Given this list of marker genes CFAP44, ANKDD1B, DIO1, AGBL2 (AGBL carboxypeptidase 2), FLACC1, SERPINI2, DNAH6, PPIL6, ENO4, ZSCAN1, ENSG00000263011, ANKFN1, CLUAP1, FRMPD2, IFT70A, DNAAF4, CCDC33, UBXN10, DNALI1, TOGARAM2 (NCBI Gene Id 165186), CFAP95, RPGR, RSPH10B2, DNAH7, CETN2, CFAP100, LINC02958, LINC00939, DAW1, TP73, DNAAF8, LINC01765, TTC23L, AKAP14, HHLA2, ENKUR, EFCAB6, SPATA33, CFAP144, GLB1L2, CCNO-DT, TTLL10 (NCBI Gene Id 254173), HCG14, FOXJ1, SEC14L3, MAT1A, HYDIN, GLTC1, LINC00589, TSPAN19, TEX26, FMO3, ENKD1, EEF1B2P5, LINC01927, C7orf57, UGT2B17, LRRIQ3, LRRC18, SMIM34, C10orf67, IQCG, SAMD15, CFAP210 (cilia and flagella associated protein 210), RSPH14, RPGRIP1L, WDR93, CCDC74B, DPCD, DNAAF11, CFAP52, DZANK1, PAPOLA-DT, LRGUK, CCDC160, FAM181A, CSRP3-AS1, LINC01435, CFAP54, TMPRSS7, PACRG, IL5RA, CC2D2A, DNAI7, ZNF391, LRRC71, CFAP77, FABP6, CDH13-AS2, SPATS1, ZNF273, SLC28A2, TEKT3, CEP126, KIF27, LINC02624, CIMAP1B, CACNG6, FAM227A, MAK, C1QTNF8, BBOF1, CFAP184, FBXO15, FAM216B, TMEM231, TMEM190, CCDC74A, LGSN, FBXW9 (F-box and WD repeat domain containing 9), NHLRC4, VWA3A, E2F3P2, CCDC13, RPL30P7, C1orf141, LINC02289, CCDC170, GJB7, ENSG00000228793, LRRC34, SLC9C2, KIAA2012, NPHP1, CFAP69, LRRIQ1, LRRC37A5P, DNAH10, C21orf58, TREM1, LRRC56, HAGHL, CCDC65, LINC02166, RABL2A, CFAP126, VWA3B, HOATZ, DNAH5, ALDH3B1, LRP2BP, DLG5-AS1, ERICH3, DYNLRB2-AS1, ROPN1L, ESRRG, ZMYND12, ANKK1, TEKT4, GBP6, IFT56, MROH9, LCA5L, PPP1R16A, ZNF475, SPACA9, SPEF2, MORN2, CCDC181, KCNJ16, DYDC2, SLC44A4, FBXL13, LINC01392, ENSG00000258752, DNAI2, CAPN13, USP2, DNAI3, ST6GALNAC2, DNAL1, TIGD4, CNGA4, TMEM212, MDH1B, MGAT4D, FAM151B-DT, CCDC78, VNN3P, CCDC60, SPATA18, WDR49, EFCAB10, LIAT1, ENSG00000236495, CCNO, LDLRAD1, MAP3K19, CSPP1, EEF1B2P4, DCDC2B, GIHCG, LMNTD1, LINC02066, C8orf34, NWD1, ODAD2 (outer dynein arm docking complex subunit 2), LCA5, TTC41P (NCBI Gene Id 253724), SLC22A4, TUBA4B, C22orf23, SAXO4, TMEM67, APOBEC4, ADPRS, GOLGA2P5 (GOLGA2 pseudogene 5), CDH26, PPP1R42, R3HDML-AS1, ZNF295-AS1, SPMIP6, CIMIP1, CFAP61, SAXO2, PLEKHS1, CD164L2, TEKT1, TPPP3, CASC2, RSPH4A, DNAI1, CFAP221, FHIP1A-DT, C22orf15, CIMIP5, DNAAF2, TMEM232, ERICH3-AS1, CATSPERD, TSNAXIP1, TP53AIP1, AK9, FSIP1, SYT8, PRSS54, LRRC26, ARMH2, FUZ, IQUB, SPAG8, CCDC39-AS1, RIBC1, LRRC10B, FHAD1 (forkhead associated phosphopeptide binding domain 1), DTHD1, TTLL9, SOX30, CFAP107, RSPH10B, STMND1, B9D1, UROC1, LINC01708, WFDC6, LMO1, ENSG00000238185, RPL13AP26, MIR7515HG, C11orf97, NME5, C10orf95, KIF23-AS1, LRRC43, MNS1, THBS3-AS1, SLC27A2, DYNLT5, GON7, PLA2G10CP, ANXA13, LRRC9, CFAP73, RSPH9, CFAP263, FANK1, FAM133GP, WDR38, HMGB1P16, DNAH3 (dynein axonemal heavy chain 3), CFAP418-AS1, FOXN4, GAS2L2, IK, CCNA1, EFCAB12, TTC14-DT (TTC14 divergent transcript), KIF9, TCTN2, ARMC3, FAM221B, PLPPR3, CLEC19A, CFAP298 (cilia and flagella associated protein 298), CCDC103, LKAAEAR1, ENSG00000234022, CFAP65, DYNLT4, WDR86-AS1, CCDC89, TEX56P, CFAP91, CIMIP2C, RUVBL2, ADGB, ENSG00000228944, ODAD3, ANGPTL5, FAM47E, LINC02265, ODAD1, ZDHHC11 (NCBI Gene Id 79844), CFAP45, C6orf52, SNTN, EFHB, RNF32, USP2-AS1, CAPN8, TTC29, CFAP90, DNAAF1, FAM181A-AS1, LRRC73 (leucine rich repeat containing 73), ANKRD66, MRLN, RGS22 (regulator of G protein signaling 22), RABL2B, LINC02731, RSPH1, ZNF584, DNAI4, EMC3, GSTA3, TTC21A, IFT57, LRRC23, SYNPR-AS1, TTC34 (NCBI Gene Id 391205), LEKR1, CFAP119, RP1, CFAP206, TGM3, FAM229B, CFAP141, AK8, CFAP99, ADGRF2P, PIERCE2, HSPBP1, ZNF19, ZDHHC1, DNAH1, LRRC46 (leucine rich repeat containing 46), NEK5 (NIMA related kinase 5), ERICH2-DT, DYNLRB2, LINC01707, CABCOCO1, ATP4B, ARMH1, CFAP276, OSCP1, SCGB2A1, CCDC146, SPAG16, STK33, CLDN8, ZNF473CR, ULK4, RIIAD1, CFAP70, ARMC2, RHPN1-AS1, SRGAP3-AS2, RPL21P54, GSTA2, ANKRD44-AS1, NRAD1, CDNF (cerebral dopamine neurotrophic factor), SMIM6, LRRC78P (NCBI Gene Id 651551), KIF6, DRC1, SAPCD1-AS1, IFT22, TEKT2, SNRPF-DT, RAB36, BTG4, DYNLT2B, EFHC1, AGR3, SPATA17, PITPNM1, CCDC17, CCDC30, CERKL, GRIN3B, FAM81B, DLEC1, VWA5B1, NAT1, MARCHF10, LPO, DNAH12 (NCBI Gene Id 8679), PLA2G10, HHATL, DNAJB13, LINC01908, OMG, LINC01091, WDR54, RPS8P5, CDHR18P, ERICH6-AS1, CIMIP2B, CROCC2, CIMIP6, DRC3, NME9, SPATA6L, ABCA13, CFAP157, CCDC157, DNAH2, C6orf118, CFAP53, TMC5, MEIG1, TCTE1, CEP19, KATNIP, MOBP, EYA1, CDHR4, STOML3, CFAP251, LINC01732, BCYRN1, CRISP2, ENSG00000269091, TRAF3IP1, DOC2A, C16orf46, CFAP300, C11orf16, PTPRT, AK7, DNAH11, CHST9, NEK2-DT, SPEF1, CAPS, CFAP20DC, ENSG00000181123, AXDND1, DYDC1, CLXN, C1orf87, AADACP1, PPOX, CATIP, ZNF20, NEK11, STOX1, LINC02300, CIBAR2, NRAV, TTLL13, CFAP47, ODAD4, IQCH, KLHDC9, ACBD3-AS1, PIERCE1, ZBBX, IQCD, CHST6, ZNF474, DCDC1, NUDT7, LINC01571, C8B, TTC16, UMODL1-AS1, LINC03086, RNU4-46P, CFAP299, RNF157-AS1, CFAP43, ZC2HC1C, SPAG6, IQANK1, CFAP96, SERPINA6, LINC01843, CFAP57, NEK10, CIMAP3, KCNRG, C11orf52, C7orf78, PRR29, CFAP58, LRRC51, ASB14, SPATA4, RWDD3-DT, RIBC2, PIH1D2, DRC12, CCDC40, KCNE1, ANKRD45, MORN5, COL28A1, CCDC190, CAPSL, AADACL2, PLPP2 (NCBI Gene Id 8612), TMEM231P1, DNAH9, TRIP13, DNAAF6, DRC7, ZNF497, ZMYND10-AS1, ECT2L, TTLL6, LNC-LBCS, CAPS2, MYCBPAP, LINC02345 (NCBI Gene Id 101928227), PLEKHG7, MAPK15, LRRC74B, C6, CCDC81, SPAG17, LPAR3, ZMYND10, DERL3, CFAP46, here is a description of the gene set: Human Gene Set: DESCARTES_FETAL_LUNG_CILIATED_EPITHELIAL_CELLS species: Homo sapiens Marker genes curated from the annotated cluster as represented in the Descartes Human Gene Expression During Development database. from publication Cao J, O'Day DR, Pliner HA, Kingsley PD, Deng M, Daza RM, Zager MA, Aldinger KA, Blecher-Gonen R, Zhang F, Spielmann M, Palis J, Doherty D, Steemers FJ, Glass IA, Trapnell C, Shendure J (PMID 33184181) The gene expression program underlying the specification of human cell types is of fundamental interest. The study authors generated human cell atlases of gene expression and chromatin accessibility in fetal tissues. For gene expression, the study authors applied three-level combinatorial indexing to >110 samples representing 15 organs, ultimately profiling ~4 million single cells. The study authors leveraged the literature and other atlases to identify and annotate hundreds of cell types and subtypes, both within and across tissues. Our analyses focused on organ-specific specializations of broadly distributed cell types (such as blood, endothelial, and epithelial), sites of fetal erythropoiesis (which notably included the adrenal gland), and integration with mouse developmental atlases (such as conserved specification of blood cells). These data represent a rich resource for the exploration of in vivo human gene expression in diverse tissues and cell types.